The following is a description of a gene set: Abnormal blood carbon dioxide level studied in species Homo sapiens An abnormality of carbon dioxide (CO2) in the arterial blood. Human Gene Set: HP_ABNORMAL_BLOOD_CARBON_DIOXIDE_LEVEL, and this is the list of marker genes: NDUFS8, ACTA1, PHOX2B, TPM2, RYR1, CACNA1S, STAC3, TPM3, ITGA7, HACD1, SELENON, LRP12, MAP3K20, MYL2